The following is a description of a gene set: species: Mus musculus Mouse Gene Set: GOBP_CONSTITUTIVE_SECRETORY_PATHWAY A process of exocytosis found in all eukaryotic cells, in which transport vesicles destined for the plasma membrane leave the trans-Golgi network in a steady stream. Upon exocytosis, the membrane proteins and lipids in these vesicles provide new components for the plasma membrane, and the soluble proteins inside the vesicles are released into the extracellular space., and this is the list of marker genes: Rab33b, Tmem167, Trappc11, Rab27a, Rab11b, Tmem167b